Given this list of marker genes Cux1, Gpnmb, Psen2, Ube3a, Tle5, Pygm, Ecsit, Recql5, Bcam, Mfap4, Tnni2 (NCBI Gene Id 21953), B2m, Stmn1, Prkaca, Tnnt3, Coq5, Ndrg2 (N-myc downstream regulated gene 2), Ech1, Gtf2h4, Atp5f1e, Mylpf, Atp5f1c, Lyz2, Tpm2, Col16a1, Cxcl14 (NCBI Gene Id 80491), Gpx3, Epha1, Pcx, Hadhb, Ube2a, Gja1, C3, Gaa, Mb, Fech, Myl1, Ptprf, Mapk7, Pik3r2, Zyx, Tcap, Nrp2, Acsl4, Aebp1, Efnb1, Smad4, Ltbp3, Fhl1, Hspb7, Bmp1, Elovl4, Sptbn1, Ptprs, Pcdh12, Rps6ka1, Lcmt1, Chst11, Col3a1, Col6a2, C4b, Lamb2, Serping1, Ephb3, Prkci, Atp5mg, Ppp1cb, Cdc25b, Crat, Fasn, Dusp14, Pdlim3, Txnip, Eci1, Myh8, Serpina1e, Il11ra1, Scp2, Echs1, Ggt1, Eya2, Dst, Pdgfra, Id2, C1qa, Pkd1, Lgals1, Mybph, Ilk, Tnnc2 (troponin C2, fast), Acadsb, Rab34, Myl9, Atp6v0b, Hp, Atp5mf, Wwp2, Myh1, Des, Eno3, Dsg2, Acsl5, Myh4, here is a description of the gene set: Selected genes down-regulated during progression through benign to malignant skin tumors formed by treatment with DMBA and TPA chemicals in the two stage skin carcinogenesis model. Chemically induced mouse skin carcinogenesis represents the most extensively utilized animal model to unravel the multistage nature of tumour development and to design novel therapeutic concepts of human epithelial neoplasia. We combined this tumour model with comprehensive gene expression analysis and could identify a large set of novel tumour-associated genes that have not been associated with epithelial skin cancer development yet. Expression data of selected genes were confirmed by semiquantitative and quantitative RT-PCR as well as in situ hybridization and immunofluorescence analysis on mouse tumour sections. Enhanced expression of genes identified in our screen was also demonstrated in mouse keratinocyte cell lines that form tumours in vivo. Self-organizing map clustering was performed to identify different kinetics of gene expression and coregulation during skin cancer progression. Detailed analysis of differential expressed genes according to their functional annotation confirmed the involvement of several biological processes, such as regulation of cell cycle, apoptosis, extracellular proteolysis and cell adhesion, during skin malignancy. Finally, we detected high transcript levels of ANXA1, LCN2 and S100A8 as well as reduced levels for NDR2 protein in human skin tumour specimens demonstrating that tumour-associated genes identified in the chemically induced tumour model might be of great relevance for the understanding of human epithelial malignancies as well. species: Mus musculus Mouse Gene Set: HUMMERICH_SKIN_CANCER_PROGRESSION_DN from publication Hummerich L, Müller R, Hess J, Kokocinski F, Hahn M, Fürstenberger G, Mauch C, Lichter P, Angel P (PMID 16247483)